The following is a description of a gene set: Human Gene Set: GOBP_PROLINE_METABOLIC_PROCESS studied in species Homo sapiens The chemical reactions and pathways involving proline (pyrrolidine-2-carboxylic acid), a chiral, cyclic, nonessential alpha-amino acid found in peptide linkage in proteins., and this is the list of marker genes: DAO, PYCR1, PRODH, OAT, NOXRED1, PRODH2, PYCR3, ALDH18A1 (aldehyde dehydrogenase 18 family member A1), ALDH4A1, PYCR2